Given this list of marker genes Bloc1s6, Dlx2, Fezf2, Sema6b, Slc32a1, Smo, Sema3a, Otp, Sox3, Plxna3, Neurod1, Neurod6, Fbxo41, Tuba1a, Uba6 (NCBI Gene Id 66644), Fez1, Gli3, Ppp1r9b, Tsku, Tmem108, Rax, Nr4a3, Ctnnb1, Ncoa1, Pou3f2, Pianp, Nrp2, Prop1, Zic3, Hap1, Mas1 (NCBI Gene Id 17171), Ptprs, Dcx, Hdac1, Crkl, Ywhae, Rab3gap1, Lhx5, Bbs2, Rara, Scn2a, Mdk, Nfix, Pafah1b1, Plxna1, Mfsd2a, Sema3e, Dab1, Atp1a2, Bax, Prdm13, Anxa3, Pitx2, Vps13b, Kcna1, Drd1, Atg16l1, Hdac2, Bbs4, Lmx1a, Mkks, Gsk3b, Crh, Btg2, Bbs1, Htr5a (5-hydroxytryptamine (serotonin) receptor 5A), Cdk5r1, Nrp1 (neuropilin 1), Ogdh (NCBI Gene Id 75674), Dlx1, Usp9x, Nkx2-6, Trp73 (transformation related protein 73), Cntnap2, Foxb1, Nr2e1, Atat1, Cdk5r2, Pten, Alk, Bcan, Fgfr2, Sct, Ubb, Pak1, Fgf13, Uqcrq, Eif2b5, Id4, Kdm6b, Abcc1, Emx2, Fxr1, Tbx3, Lypd6, Drd2, Xrn2, Mme, Fxr2 (NCBI Gene Id 23879), Lrp8 (low density lipoprotein receptor-related protein 8, apolipoprotein e receptor), Csf1r, Pomt2, Kcnq2, Srf, Pomgnt1 (protein O-linked mannose beta 1,2-N-acetylglucosaminyltransferase), Ezh2, Aldh1a3, Large1, Nefl, Atp2b4, Kif3a, Ndnf, Zic1, Gsx1, Zbtb18, Tbr1, Epha5 (Eph receptor A5), Srd5a2, Zeb2, Nf2, Mecp2, Dclk2, Nkx2-1, Tsc1, Lef1, Xrcc1, Wnt3a, Fgfr1, Kirrel3, Casp3, Crk, Kif14, Cdk5, Nhlh2, Reln, Nf1, Prox1, here is a description of the gene set: The progression of the limbic system over time from its initial formation until its mature state. The limbic system is a collection of structures in the brain involved in emotion, motivation and emotional aspects of memory. species: Mus musculus Mouse Gene Set: GOBP_LIMBIC_SYSTEM_DEVELOPMENT